The following is a description of a gene set: Human Gene Set: GOBP_SYNAPTIC_VESICLE_CLUSTERING The process that results in grouping synaptic vesicles in presynaptic structures. studied in species Homo sapiens, and this is the list of marker genes: SYN2, SYN1, BRSK2, BRSK1, PCLO, BSN, SYN3, SYNDIG1, RAB3A, NLGN2, CDH2, CTBP1 (NCBI Gene Id 1487), CTNNB1, NLGN1, PCDH17, NRXN1, PTEN